Given this list of marker genes IL1B, HRH3, STX1A, UNC13B, FBXO32, RBL2, NOS1, PPP2CB, TNF, SYN1, NECTIN2, SLC6A3, TDO2, TH, AMPH, ADORA2A, MAPK14, SLC6A4, ACHE, SCAMP2, SLC6A2, TNFRSF11B, TSC2, CDC25C, SLC6A1, TGFB1I1, ITGB3, IL1R1, SLC5A7, TPH2, AGT, DBH, here is a description of the gene set: Human Gene Set: WP_MONOAMINE_TRANSPORT species: Homo sapiens Monoamine transport